Given this list of marker genes Hsp90ab1, Ift52, Gpr179, Ptch1, Omp, Ift20, Drd4, Hsp90aa1, Map2, Rgs7, Grk3, Slc32a1, Rgs11, Mapk8ip1, Ift57, Src, Cobl, Cyfip1, Taok2, Cdkl5, L1cam, Smo, Calb2, here is a description of the gene set: Mouse Gene Set: GOCC_DENDRITE_TERMINUS studied in species Mus musculus A structure at the distal end of a dendrite adapted to carry out a specific function, e.g. dendriole.